The following is a description of a gene set: Mouse Gene Set: REACTOME_CROSS_PRESENTATION_OF_SOLUBLE_EXOGENOUS_ANTIGENS_ENDOSOMES species: Mus musculus Cross-presentation of soluble exogenous antigens (endosomes), and this is the list of marker genes: Psme2, Adrm1 (NCBI Gene Id 99832), Psmb6, Psmb1, Psmc6, Psmb4, Mrc1, Psmd14, Psmb8, Cd207, Psma3, Psmb3, Psmd2, Psmc3, Fcgr1, Psmd3 (NCBI Gene Id 52891), Psme1, Psmd12, Psmb2, Psmd11, Psmc2, Psme2b, Psmd6, Psma1 (proteasome subunit alpha 1), Psma2, Psmd1, Psma4, Mrc2, Psmc1, Psmc5, Psmd7, Psma5, Psmb7, Psmb10, Psmd13, Psmd8, Psmb5, Psma6, Psmc4, Psma7